Given this list of marker genes Tgfbr3, Acvr1b, Inhba, Spry1, Pdcd4 (NCBI Gene Id 28204), here is a description of the gene set: Mouse Gene Set: GOBP_CARDIAC_FIBROBLAST_CELL_DIFFERENTIATION species: Mus musculus The process in which a relatively unspecialized cell acquires the specialized structural and/or functional features of a cardiac fibroblast. A cardiac fibroblast is a connective tissue cell in the heart which secretes an extracellular matrix rich in collagen and other macromolecules.